Given this list of marker genes Kcnk12 (NCBI Gene Id 210741), Kcnk13, Kcnk10, Kcnk3, Kcnk18, Kcnk4, Kcnk2, Kcnk1, Kcnk6, Kcnk15, Kcnk9, Kcnk16, Kcnk5, Kcnj4, Kcnj2, Kcnk7, Kcnj12, Kcnj14, here is a description of the gene set: Mouse Gene Set: REACTOME_PHASE_4_RESTING_MEMBRANE_POTENTIAL studied in species Mus musculus Phase 4 - resting membrane potential